Given this list of marker genes S100B (S100 calcium binding protein B), IFRD1, SLC18A1, NKX3-1, FILIP1L, EDC4, FBXO42 (NCBI Gene Id 54455), WDR45B, CKB, SLC4A1, COQ8A, PAEP, PDE6H, MAL, ABCB4, TOB1, TNFRSF21, RPS16, LRRC37BP1, ADAMDEC1, BHMT (betaine--homocysteine S-methyltransferase), LGI1 (leucine rich glioma inactivated 1), PBLD, DNASE1L3, RUBCNL, KIR3DX1, CWH43, LGMN, PLS1, KIF13A, IFT57, MED21, RASSF9 (NCBI Gene Id 9182), TDRKH, NELL2, PLK2, IL1RL2, SOX21, SPATA2, AREG, MYH4, SLC15A2, SLC6A13, RGS1, GIPR, UBQLN3, LPCAT3, CD1C, PKIA, TAF9B, LILRB4, MATN2, ETV3 (ETS variant transcription factor 3), ZNF395, PTGER4, ADIPOR1, KDM5A, RPL7, IP6K1, LONP2, EEF1D, WDHD1, FCER1A, CCNH, MGST2, SYPL1, HSPH1, N4BP3, ARHGAP5, ASPSCR1, ABCB1, ZFP36, DKFZP434A062, RASA1, LEPR, CLK1, FZD6, CPD, APBA2, CEBPG, OLR1, FOXP3, NBEA, TOPORS, FKBP11, LRRC40 (NCBI Gene Id 55631), PRELID3B, EDDM3A, MMP3, HAUS7, DENND5A (DENN domain containing 5A), NID2, MYO7B, KLHL11, NAGPA, HKDC1 (hexokinase domain containing 1), NBL1, MATN1, NEIL1, FBXO31, DSE, SNRNP200, JMJD6, MXD4 (NCBI Gene Id 10608), VAV3, RTN1, TSN (translin), RUNX3, ADRA1D, HNRNPA1, TCEAL2, ITM2C, COX16, SEMA3D, TLX1, SPINT3, SVIL, PLXDC1, GSTCD, NIPSNAP3B, CHODL, SOS2, PIK3IP1, SSBP2, CCR7, ZBTB18, PIK3R3, PLCH1, SESN1, BIRC3, PABPC3, SLC39A8, CCT6B, SKI, MGP (NCBI Gene Id 4256), TLE2, SLC7A5, OR7C1, PLEKHA6, EPYC, ASB13, GPX2, EIF1, RIPPLY3, QPCT, IGF2BP3, RPL23, ITGA5, EXD2, CD6, BTG1, PRKAB2, RRAGB, OSER1, CXCR3, TGFB1, GAS2L1, GUCY1A2, EEIG1, OAT, MAFF, CRYL1, LSM12, ADGB, CHRD, MYOT, ST7, TNFAIP3, ELK3, TOE1, PPP2R3C, METTL2B, SRSF3, MVB12B, AQP1, GNAQ, NDUFAF5, OSGIN2, CST1, ZBTB3, TNF, MOAP1 (NCBI Gene Id 64112), UBE2D4, LMNA, NUP214 (NCBI Gene Id 9680), VAMP2, PABPC1, SRSF6, BEX1, MKRN7P, ZNF136, POLR2J2, TGFB1I1, TRA2B, ASNSD1, CAVIN3, TUBB2A, GABARAPL1, here is a description of the gene set: Genes up-regulated in comparison of CD8 T cells with progressing HIV infection versus those with controlled HIV infection. CD8+ T cells in chronic viral infections like HIV develop functional defects such as loss of IL-2 secretion and decreased proliferative potential that are collectively termed exhaustion1. Exhausted T cells express increased levels of multiple inhibitory receptors, such as Programmed Death 1 (PD-1). PD-1 inhibition contributes to impaired virus-specific T cell function in chronic infection because antibody-mediated blockade of its ligand, Programmed Death Ligand 1 (PD-L1) is sufficient to improve T cell function and reduce viral replication in animal models. Reversing PD-1 inhibition is therefore an attractive therapeutic target, but the cellular mechanisms by which PD-1 ligation results in T cell inhibition are not fully understood. PD-1 is thought to limit T cell activation by attenuating T cell receptor (TCR) signaling. It is not known whether PD-1 ligation also acts by upregulating genes in exhausted T cells that impair their function. Here, we analyzed gene-expression profiles from HIV-specific CD8+ T cells in patients with HIV and show that PD-1 coordinately upregulates a program of genes in exhausted CD8+ T cells from humans and mice. This program includes upregulation of basic leucine transcription factor, ATF-like (BATF), a transcription factor in the AP-1 family. Enforced expression of BATF was sufficient to impair T cell proliferation and cytokine secretion, while BATF knockdown reduced PD-1 inhibition. Silencing BATF in CD4+ and CD8+ T cells from chronic viremic patients rescued HIV-specific T cell function. Thus inhibitory receptors can cause T cell exhaustion by upregulating genes – such as BATF – that inhibit T cell function. studied in species Homo sapiens Human Gene Set: GSE24081_CONTROLLER_VS_PROGRESSOR_HIV_SPECIFIC_CD8_TCELL_UP from publication Quigley M, Pereyra F, Nilsson B, Porichis F, Fonseca C, Eichbaum Q, Julg B, Jesneck JL, Brosnahan K, Imam S, Russell K, Toth I, Piechocka-Trocha A, Dolfi D, Angelosanto J, Crawford A, Shin H, Kwon DS, Zupkosky J, Francisco L, Freeman GJ, Wherry EJ, Kaufmann DE, Walker BD, Ebert B, Haining WN (PMID 20890291)